Given this list of marker genes NOP56, SNRPB2, ZNF706, SLC16A6, HDHD3, VPS29, RSU1, WDR74, RPGRIP1, VPS50 (VPS50 subunit of EARP/GARPII complex), ZMPSTE24, DHODH, STX7, E2F8, EFS, YIF1A, CPNE2, SLC26A10P, HLA-DOA, NPL, DEPDC7, INTS10, S100A1, LSM4, FOXL1, AQR, RAD51AP1, TAGLN2, TMEM11, GCFC2, THOC6, NDE1, FSTL4, FMOD, BET1, BAMBI, ARL1, TSPO, GDAP2, APLN, POLR1E, ANP32E, TEX9, EXOSC1, MTTP (NCBI Gene Id 4547), NDUFA5, CILP2, HEATR1, CSMD3, MEPE, DCUN1D3, RFLNA, ROCK2, CENPV, COMMD9, MED4 (NCBI Gene Id 51757), PSMD6, DNAH6, ACTL6A, BUB3, ZNF830, SEPSECS, PKP2, PUM3, PBDC1, LAMA5, UBTD1, AP1AR, DSCC1, TMEM236 (transmembrane protein 236), ABCA1, GLMN, CORO2A, DKC1, ZNF511, NTHL1, CRB1, MED18, ZFTA, MOG, CYSLTR1, KCNJ12, RTKN (rhotekin), NDUFA2 (NADH:ubiquinone oxidoreductase subunit A2), HAUS2, F2RL2, CIART, ERCC6L2, MRPL30, SLC2A6, PTCD2 (NCBI Gene Id 79810), GGT7, PRDX4, TEDC2 (NCBI Gene Id 80178), SLC43A3, GPR20, ABITRAM, ADGRA3, CUL1, RTCA, BOC, DGCR8, DACH2, UTP25, SLC31A1, MRPL49, SLC35D1, CDK7, SRP19, SNX10, RPE65, LPP (LIM domain containing preferred translocation partner in lipoma), RIT1, DHFR, CTNNBL1, HS2ST1, APRT, BCL2L2, ECRG4, CS, FBXO5, CLSPN, PEX12, KCNJ9, NAT10, PDGFC, EXOSC8, RAE1, E2F5, EIF1AY, SCFD1, NASP, ADH4, ACAT1, CASP3, KLHL7, NIT2, ACP6, EXOSC9, SOBP, RABEPK, XPO1 (exportin 1), PDK1, SRSF3, AKAP1, SEC61G, FBXO30, DNAJC2, CATSPER2, SLCO3A1, TSNAX, PRL, CYSLTR2 (NCBI Gene Id 57105), SDHAF3, KRT33B, BMF (NCBI Gene Id 90427), SANBR, RABIF, MRPL18, NOP2, RETSAT, CCT6A (chaperonin containing TCP1 subunit 6A), NDUFAF1, RAB3A, APOA2, CYB561, SEH1L, TLR9, SPEF2, EME1, EIF3K (eukaryotic translation initiation factor 3 subunit K), MSANTD4, MRPL46, METTL9, CBFA2T3, GMDS (NCBI Gene Id 2762), YTHDF2, PIN1, FGF7, NCEH1, GEMIN2, MKKS, RPL35, ATPAF2, TMEM237, OGFRL1, BCCIP, EFNB1, KCNE5, PPAN, PWP2, SMU1, HCFC2, KANK3, KIAA0825, METAP1, EPCAM, TLL2, RER1, RPL27A, here is a description of the gene set: studied in species Homo sapiens from publication Nurieva RI, Chung Y, Hwang D, Yang XO, Kang HS, Ma L, Wang YH, Watowich SS, Jetten AM, Tian Q, Dong C (PMID 18599325) Genes down-regulated in comparison of T follicular helper (Tfh) cells versus Th17 cells. Human Gene Set: GSE11924_TFH_VS_TH17_CD4_TCELL_DN After activation, CD4+ helper T (Th) cells differentiate into distinct effector subsets. Although chemokine (C-X-C motif) receptor 5-expressing T follicular helper (Tfh) cells are important in humoral immunity, their developmental regulation is unclear. Here we show that Tfh cells had a distinct gene expression profile and developed in vivo independently of the Th1 or Th2 cell lineages. Tfh cell generation was regulated by ICOS ligand (ICOSL) expressed on B cells and was dependent on interleukin-21 (IL-21), IL-6, and signal transducer and activator of transcription 3. However, unlike Th17 cells, differentiation of Tfh cells did not require transforming growth factor b (TGF-b) or Th17-specific orphan nuclear receptors RORa and RORg in vivo. Finally, naive T cells activated in vitro in the presence of IL-21 but not TGF-b signaling preferentially acquired Tfh gene expression and promoted germinal-center reactions in vivo. This study thus demonstrates that Tfh is a distinct Th cell lineage.